Given this list of marker genes XPO4, MAD1L1, RGPD3, POM121C, RAE1, KPNA1, CHMP2B, ENY2, TPR, NUP42, CHMP1B, RAN, SUMO1, NUP88 (nucleoporin 88), NUP93 (NCBI Gene Id 9688), CHMP6, NUP210, CHMP3, POM121L2, XPO7, RGPD8, AGFG1, NXT1, CHMP4BP1, RANGAP1, CHMP4A, CHMP2A, NUP37, NUP50, CHMP7, MAD2L1, AAAS, NUP188, KPNA3, CETN3, POM121, PCID2 (NCBI Gene Id 55795), NUP35, CHMP4B, RGPD1, RANBP2, GLE1, NUP43, SEC13, SNUPN, NPIPA1, POM121B, NUP153, NUP133, MVP, NUTF2, VPS4A, RANBP1, RGPD4, NXF1, NUP54, CHMP4C, NXT2, BICD2, NUP210L, NUP214, TNKS, DDX19B, PARP11, NUP160, MCM3AP, EIF5A, RANBP17, RGPD2, NUP62, VPS4B, IPO5, AHCTF1, SEH1L, RGPD6, NUP98, RGPD5, NPAP1, KPNB1, XPOT (NCBI Gene Id 11260), NUP155, MX2, CHMP1A, IPO7, NUP85, NUP107, NUP58, CHMP5, CETN2, ZC3HC1, SENP2, KPNA4, NUP62CL, NUP205, NDC1, UBE2I, here is a description of the gene set: studied in species Homo sapiens Human Gene Set: GOCC_NUCLEAR_PORE A protein complex providing a discrete opening in the nuclear envelope of a eukaryotic cell, where the inner and outer nuclear membranes are joined.